Given this list of marker genes CPOX, SPP1, NUP107, MYO1E, NUP205, COQ8B, AKR1D1, NUP160, PYGM, ANLN, HMBS, NPHS1, INF2, ARHGDIA, WT1, UROS, MT-CO1, TSC1, IFT56, MPV17 (mitochondrial inner membrane protein MPV17), MAGI2, GAPVD1, DMD, PTPRO, HGD, PAX2, NUP37, TRPC6, TBC1D8B, STAT4, PLCE1, COL4A3, NPHS2, EMP2, OBSCN, CLTRN, MT-CO3, SLC6A19, CD2AP, ATP11C, APOL1, TSC2, CPT2, LPIN1, ACTN4, ABCC2, SAT1, DAAM2, UROD, NUP133, NUP93, BLVRA, GATA1, NUP85, IRAK1, ANKFY1, ARHGAP24, ALAD, CRB2, here is a description of the gene set: Anomalous physical appearance (color, cloudiness, clarity) or odor of urine. Human Gene Set: HP_ABNORMAL_MACROSCOPIC_URINE_APPEARANCE Abnormal macroscopic urine appearance studied in species Homo sapiens